The following is a description of a gene set: species: Homo sapiens Human Gene Set: GOBP_BLOOD_VESSEL_MATURATION A developmental process, independent of morphogenetic (shape) change, that is required for a blood vessel to attain its fully functional state., and this is the list of marker genes: DDIT3, CDH5, S1PR1, RECK, LYL1, MMP2, ACVRL1